The following is a description of a gene set: Genes up-regulated in CD4 T cells: healthy versus CLL (chronic lymphocytic leukemia)l. from publication Görgün G, Holderried TA, Zahrieh D, Neuberg D, Gribben JG (PMID 15965501) species: Homo sapiens To examine the impact of tumors on the immune system, we compared global gene expression profiles of peripheral blood T cells from previously untreated patients with B cell chronic lymphocytic leukemia (CLL) with those from age-matched healthy donors. Although the cells analyzed were not part of the malignant clone, analysis revealed differentially expressed genes, mainly involved in cell differentiation in CD4 cells and defects in cytoskeleton formation, vesicle trafficking, and cytotoxicity in CD8 cells of the CLL patients. In coculture experiments using CLL cells and T cells from healthy allogeneic donors, similar defects developed in both CD4 and CD8 cells. These changes were induced only with direct contact and were not cytokine mediated. Identification of the specific pathways perturbed in the T cells of cancer-bearing patients will allow us to assess steps to repair these defects, which will likely be required to enhance antitumor immunity. Gene expression profiling was performed to determine whether CLL cells induce changes in T cells in patients with CLL. Human Gene Set: GSE8835_HEALTHY_VS_CLL_CD4_TCELL_UP, and this is the list of marker genes: CRLF3, FXYD6, LPIN2, OASL, IMMP1L, CNOT4 (NCBI Gene Id 4850), ATP10A, PCDHB16, WASF1, CHKA, UBC, EGFL7, SFTPD, TIMD4, LIME1, TAFA2, ABCA5, CD72 (CD72 molecule), SYT4, ST3GAL5, PRICKLE2, GLA, UBE2D2, ADSS1, POLR3G, NMD3, DTNA, HLA-A, RORC, PRNP, NTMT2, RGCC, TALDO1, LURAP1L, EPB41L1, DUSP15, UACA, MAP2, CRELD2, IFI44L, SAP30, TRIM45, NUP35, THEM4, RFC3, N4BP1, GPR84, GJB5, IGFBP3, GBGT1, DUSP14, APOD, ERF, TNK2, TCF7L2, IFIT2, CRISPLD2 (NCBI Gene Id 83716), SMCR8, PMEPA1, TMEM94, RNH1 (NCBI Gene Id 6050), PLD4 (phospholipase D family member 4), STAB1, APOE, RBM43, UBAP1, ITSN1, MMP13, ARHGEF28, ITGB7, CCND1, DOP1B, BCOR, ASL (NCBI Gene Id 435), ID3, LANCL3 (NCBI Gene Id 347404), PTK2, SLC9A5, SNX18, ACYP2, ACTB, SERPINB8, PSMD8, CYP4F3, DDX51, ELK3, CCL7, OGFRL1, AOPEP, HDC, XKR8, LCOR, TTC17, BPIFB2, SCN3B (NCBI Gene Id 55800), FAM241A, RAB20, ACKR3, EZR, ALOX5, DPH5, ALCAM, OAS1, ARMCX3, CCDC125, GCNT1, SLC26A4, TRIM13, FBXO4, RNASE4, SLC35B1, GPR88, GCLM, HOXB1, NT5C3A, ATP1A4, CPXM2, AGFG1 (NCBI Gene Id 3267), TRIP11, AMIGO2, MS4A8, HOXD8, CARMIL1, SULT1A1, LHFPL6, CTNNAL1, GPR182, CYB561D1, SGCB, NIFK, TRIB3, GNB3, DUSP4, CADM1, VAMP1, SAMSN1, FAM111A, PRDX4, DAXX, RGS3, TNFSF9, LRRC42, NUDT17, AMN, TMTC1, IFIT3, SPATA13, STXBP1, UBXN8, CAPG, TEX55, SELENOF, PKP4, DPH2, TBL3, KANSL3, TENT5A, TXN, RYR1, C2, MED7, USP2, EYA4, KCNJ9, CCNYL1, FBLN2, CD69, CWC22, PLPPR1, KLRK1, ABCC6 (ATP binding cassette subfamily C member 6), DDX4, FOXRED2, CMPK2, NEK8, CBX4, PMP22, KATNA1, ZNF707, FYTTD1, ITIH4, KAT5, IL15, MLXIPL, HRH4 (histamine receptor H4), NTAQ1, IL22RA2, PGBD5, CCND2, DCPS, CASP1, SYNE2, CXorf38, CTSF, ETV1, FADS6, CD207, HAT1, RARB